Given this list of marker genes LRP2, SLC17A4, FGD5, TRPM6, RAC1, PTPRH, FERMT1, ABCA7, FOLR1, TIRAP, ACE2, BBS2, SLC38A4, PROM1, AMN (amnion associated transmembrane protein, NCBI Gene Id 81693), SLC46A1, HCN1, DMTN, KCNK1, NME1, SHISA7, ARL13A, SLC26A6, DAGLA, PDE9A, PROM2, INPP5K, FSCN1, GNAT1, SLC34A3, UNC5A, HPCA, SLC26A2, GABRA3, GNAT2, TTC8, TMEM231, KCNN4, HHIP, BBS7, ARF4 (ADP ribosylation factor 4), LAMP5, USH2A, PHLPP2, JCAD (junctional cadherin 5 associated), IQCE, PLCG1, TLN1, PIP5K1C, NHERF1, CNGA1, DHRS3, SLC28A2, MYO1D (myosin ID), SLC12A5, SPTBN1, CEACAM1, PKD2L1, ITGA8, STX4, ATP6AP2, SLC39A6, MOSMO, AMN1, GABRA4, FGR, C2CD5, PACSIN1, S100P, SLC3A1, PKD1, SLC20A2, CACNG8, SYNE2, ARL13B, ARHGEF4, VEZT, CD44, DDN, BBS1, CFL1, BBS4, SLC9A3, KCNC1, APP, ADORA1, GABRA2, PDE6B, SNAP29, ITGA5, SLC28A1, PDPN, EPHA2, TRPV4, CA4, DRD1, TBC1D10C, MUC20, RHO, ABCB1, PDZK1, KSR1, GABRA6, SHANK2, PLXND1, TAS2R43, SYTL1 (NCBI Gene Id 84958), MTTP, SLC7A8, PIEZO1, MYO10, SLC11A2, PLEK, FERMT2, PEX19, BBS9, PDE6A, PSD2, PIP5K1A, KCNC2, PKD1L1 (polycystin 1 like 1, transient receptor potential channel interacting), SLC1A2, PLA2G4F, TTYH1 (NCBI Gene Id 57348), TESC, CLRN2, ADGRE2, ITGB3, GABRG2, IZUMO1R, SLC17A3, CYS1, GRIA1, SCNN1A, VASP, DOCK8 (dedicator of cytokinesis 8), TMEM67, P2RY12, ATP1B2, AIF1L, CNTNAP2 (contactin associated protein 2), SLC22A5, EPS8, TAS2R4, UTRN, HCN2, DPEP1, CNGB1, GAP43, MXRA8, PSD (pleckstrin and Sec7 domain containing), SRC, UMOD, THY1, BBIP1, EVC2, CIB1, ANK1, CLCN3, SH2D3C, SLC6A19, ITLN1, FSCN3, KCNC3, SCIMP, HSP90AA1, EPS15, SLC7A11, DMD, ADCY3, APPL2, CLTB, DPP4, RIGI, RIPOR2, GPR161, SHISA6, TMEM17, SSTR3, GPR37L1, RAB35, SLC26A4, B4GALT1, MTMR9, AQP8, ROBO2, SLC27A4, CLTRN, DLC1, ATP2B2, EHD3, PLCG2 (NCBI Gene Id 5336), TSPEAR (NCBI Gene Id 54084), PLD2, SLC5A1, EPS8L2 (NCBI Gene Id 64787), LCP1, PDE4A, KCNA2, OPRD1, ADORA2A, CDKL5, ITGA3, PDE6H, ARPC2 (NCBI Gene Id 220721), PLEK2, CLASP2, PLEKHO1, ITGAV, SHISA9 (NCBI Gene Id 732120), MYO1C (myosin IC), EPS8L3, MTMR6, RPS3, APC, DRD2, SPRY4, FZD9, AIF1, GPI, TRPV1, CDHR2, SLC5A6, GABRE, PAK1, TWF1, MYO6, BRWD1, PLB1, PSD4, AKT2, NF2, RAB34, GPR88, CEACAM20, KANK1, SLC28A3, SLC34A2, EVC, CD36, TACR3, EHD1, PDXP, MPP2, CLCN2, ARPC1A, SNTG1, PODXL, ANTXR1, THEM4, MFSD10, ADAM17 (NCBI Gene Id 6868), BMX (NCBI Gene Id 660), SPATA13, MAPT, ROM1, SLC12A2, WWC1 (WW and C2 domain containing 1), SLC6A18, INSR, CASK, PACSIN2, PKHD1L1, ABCG2, APC2, RAB25, ARF6, ATP6V0A4, MTSS2, MCHR1, PLEKHA1, FCRL3, SLC26A3, ITGB1, SHANK3, SLC34A1, DLG1, HIP1R, GPER1, PTCH1, TXNDC15, GABRG1, MICALL1, GABRA5, FGD2, SLC9A5, KCNC4, NDRG4, SEPTIN2, CTNNB1, CYBRD1, EGFR, HLA-G, SGCE, TAS2R46, PPP1R9B, EPB41L3, NCKAP1, SH3BGRL3, GNA13, DIAPH1, MACF1, LIMA1, CORO1C, TCTN2, BBS5, CUBN, GUCY2D, GABRG3 (gamma-aminobutyric acid type A receptor subunit gamma3), EPB41L5, SPRY2, FFAR4, CDHR1, AKAP5, ATF4, CNGA2, ARHGAP45, TPM1, SLC22A12, CSPG4, SHISA8, FAM107A, RAB8A, PTPRJ, NAPEPLD, ERBB2, EEF1A1, PRCD, PKD2, RHOA, IFIT5, SLC7A9, CA9, ARHGEF2 (NCBI Gene Id 9181), SLC7A5, BVES, EFCAB7, PSD3, CDHR5, SLC19A1, RASGRP2, FAP, GPR157, SMO, CNGA4, KCNB1, DRD5, EZR, ADGRV1, PDE6G (NCBI Gene Id 5148), GABRA1, GABBR1, MAPRE1, GNA12, EPS8L1, AQP1, PALM, TCTN3, SLC6A6, MSN, SH3YL1, here is a description of the gene set: Human Gene Set: GOCC_CELL_PROJECTION_MEMBRANE species: Homo sapiens The portion of the plasma membrane surrounding a plasma membrane bounded cell surface projection.